Given this list of marker genes STK11, ADIPOQ, PRKAA2, ADIPOR2, MLXIPL, PRKAG2, PRKAB2, ADIPOR1, here is a description of the gene set: studied in species Homo sapiens part of: Integration of energy metabolism AMP-activated protein kinase (AMPK) is a sensor of cellular energy levels. A high cellular ratio of AMP:ATP triggers the phosphorylation and activation of AMPK. Activated AMPK in turn phosphorylates a wide array of target proteins, as shown in the figure below (reproduced from, with the permission of D.G. Hardie). These targets include ChREBP (Carbohydrate Response Element Binding Protein), whose inactivation by phosphorylation reduces transcription of key enzymes of the glycolytic and lipogenic pathways. Reactome Pathway: AMPK inhibits chREBP transcriptional activation activity